Given this list of marker genes MT-CO2, COQ4, NDUFAF6, SDHB, ECHS1, LIPT2, HPDL, MTRFR, GFM2, HSD17B10, POLRMT, KARS1, SLC39A8, SUCLG1, NDUFB7, COG8, MT-CO3, FARS2, MT-TW, NFU1, SQOR, MECR, LYRM7, FBXL4, MT-ND6, VARS2, MPV17, MT-CO1, LYRM4, HTRA2, MT-TS2, MT-ND5, SV2A, CYP27A1 (NCBI Gene Id 1593), MRPL39, MT-TQ, MT-TF, DNM1L, MT-ND4, COX11, MRPS34, MT-TH, MT-TL1, MT-ND1, COX16, TEFM (NCBI Gene Id 79736), GCSH, here is a description of the gene set: Human Gene Set: HP_ABNORMAL_BRAIN_LACTATE_LEVEL_BY_MRS species: Homo sapiens A deviation from normal of the level of lactate in the brain identified by magnetic resonance spectroscopy (MRS). Abnormal brain lactate level by MRS